The following is a description of a gene set: Embryonal tumours of the central nervous system (CNS) represent a heterogeneous group of tumours about which little is known biologically, and whose diagnosis, on the basis of morphologic appearance alone, is controversial. Medulloblastomas, for example, are the most common malignant brain tumour of childhood, but their pathogenesis is unknown, their relationship to other embryonal CNS tumours is debated, and patients' response to therapy is difficult to predict. We approached these problems by developing a classification system based on DNA microarray gene expression data derived from 99 patient samples. Here we demonstrate that medulloblastomas are molecularly distinct from other brain tumours including primitive neuroectodermal tumours (PNETs), atypical teratoid/rhabdoid tumours (AT/RTs) and malignant gliomas. Previously unrecognized evidence supporting the derivation of medulloblastomas from cerebellar granule cells through activation of the Sonic Hedgehog (SHH) pathway was also revealed. We show further that the clinical outcome of children with medulloblastomas is highly predictable on the basis of the gene expression profiles of their tumours at diagnosis. studied in species Homo sapiens Human Gene Set: POMEROY_MEDULLOBLASTOMA_PROGNOSIS_UP Top marker genes in medulloblastoma associated with good response to treatment (good outcome). from publication Pomeroy SL, Tamayo P, Gaasenbeek M, Sturla LM, Angelo M, McLaughlin ME, Kim JY, Goumnerova LC, Black PM, Lau C, Allen JC, Zagzag D, Olson JM, Curran T, Wetmore C, Biegel JA, Poggio T, Mukherjee S, Rifkin R, Califano A, Stolovitzky G, Louis DN, Mesirov JP, Lander ES, Golub TR (PMID 11807556), and this is the list of marker genes: COL6A2, RTN1, SLCO2A1, TERF1, GAP43, IDUA, ATRX, MYL6, REG1A, CALML3, REG3A, SATB1, AMT, NTRK3, REEP5 (receptor accessory protein 5), SRP54, RASL10A, ACADVL, NHLH1, BRME1, ECH1, ASIC1, TMSB4X, PLOD1, DYNLT1, NUP62, KMT2A, CRMP1, ELN, DVL3, NPIPB3, NBL1, PTK7, GNAS, USP4, GTF3C1, NPIPA1, TLE5, RALGDS, IRF3, AP3B2 (NCBI Gene Id 8120), ETV4, ACSL1, APOD, ZKSCAN7, AIP, NDN, GPS2